Given this list of marker genes WNT9A, CASZ1, STK35, DLX3, LIN54, AMY2A, RAB37, LRRC17, HAUS4, KCNH5, GDNF, WBP11, NLK, HOXA2, RANBP9, BHLHE40, CYLD, MBP, LARP4, ACBD3, TRIM63, SHISA6, RBM3, LOX, PPP1CC, CXCL14, KLF5, GATA3, MBNL2, KLHL23 (kelch like family member 23), DNAJA2, EPG5, ZMYND8, SLC9A1, TSSK3, HOXC6, IKZF2, ZNF532, KANSL1, SEMA3A, CCDC126, PRDM1, HTR2C, PARP8, PAF1, G3BP2, CPEB4, OTX1, CTNND2, CD52, FIGN, JPH1, ENTREP1, EFNA1, AMOT, CDKN1A, TEAD2, RERE, MIR7-3HG, TCF12, MBIP, SH2D1A (NCBI Gene Id 4068), ARHGAP6, ADNP, PUM2, KRT20, U2AF1L4, BRINP3, ELAVL4, ITGA6, RBBP7, KIZ, CUEDC1, PRRX1, WDR49, OR2L13 (olfactory receptor family 2 subfamily L member 13), NDST2, FES, KHDRBS1, SREK1, CNGB3, HOXB7, ELMO1, DOCK4, ENPP2, TIE1, SLC7A11, SEM1, CD96, SLC12A8, KLHL5, DNAJC3, SYNCRIP, E2F4, ITPR3, CER1, SKIL, NDUFS1, RAB1B, CD36, ISL1, NEXN, NUFIP2, UBE3A, BCL6, RANBP6, PSENEN, MPZ, LGI1, KCNJ1, PYGM, ZNF775, ADAMTSL1, PCDH8, RCN1, JMJD1C, EEF1B2, TBL1XR1, EPHA7, SCNN1A, GPBP1, ADCY6, MTMR10, SLAIN1, ZNF654 (zinc finger protein 654), BHLHE22, TNIP3, BDNF, EMILIN1, UBR1, NCDN, TLCD3B, RTL3, TIMD4, KCNK10, DOLPP1, GCNT3 (NCBI Gene Id 9245), VCP, ETS1, EIF4ENIF1, TNNC1, HIVEP1, WNT8B, GSDMA, WNT4, PMCHL2, TUBB4A, EPB41L3 (erythrocyte membrane protein band 4.1 like 3), RNF38, GRB2, LUC7L3, TNMD, PAK1IP1, SRGN, MAP1B, PXN, LAMTOR3, TMEM86A, CALCRL, RBX1 (NCBI Gene Id 9978), OTP, PROX1, NSD1, PHF21A, FSTL5, NCKAP5, DUSP10, ATG2B, FGF17, PMCHL1, DLX2, RELCH, KRTAP11-1, ZNF277, SEMA4C, SDC1, IP6K2, MYH4, SPATA31G1, BHLHA15, NEDD4, HOXC4, ZIC2, USP54, HEPACAM2, TMEM258, DSTN, SRSF6, CA5B, FEN1, DLL4, KCTD4, CPB1, SORBS1, NIPBL, DST, TNS2, RGS3, WFIKKN2, ADGRB3, FILIP1, SENP3, ATF7IP, here is a description of the gene set: Genes having at least one occurrence of the motif NNNNNNNGKACNNNNTGTTCTNNNNNN in the regions spanning 4 kb centered on their transcription starting sites. This matches the NR3C1 transcription factor binding site V$GR_01 (v7.4 TRANSFAC). species: Homo sapiens Human Gene Set: GR_01